The following is a description of a gene set: studied in species Mus musculus The portion of the actin cytoskeleton, comprising filamentous actin and associated proteins, that lies just beneath the plasma membrane. Mouse Gene Set: GOCC_CORTICAL_ACTIN_CYTOSKELETON, and this is the list of marker genes: Anln, Wasl, Flot1, Septin2, Mlph, Cobl, Cdh2, Myh9, Sptbn5, Gmfg, Ppp1r9b, Myzap, Tmc2, Myadm, Gys2 (glycogen synthase 2), Flot2, Actn3, Cfl1, Ppp1r9a, Cdh1, Hfe, Mtss2, Pls1, Calb1, Actn1, Shroom4, Snx9, Akap13, Slc2a1, Plekhh2, Cald1, Myrip, Coro1a, Trpv4, Myo1e, Wdr1 (NCBI Gene Id 28041), Llgl1, Maea, Sptb, Pjvk, Pdlim2, Rtkn, Piezo2, Hcls1, Rdx, Sptbn1, Cib2, Actn2, Pvalb, Iqgap1, Hip1, Prkcb, Ocm, Cotl1, Eef1a1, Cttn, Dbnl, Nf2, Sptbn2, Dbn1, Spta1, Scnn1a, Myo1a, Krt19, Fchsd1, Gmfb, Myo1f, Myh2, Med28, Cap1, Vcl (vinculin), Actr2, Pstpip1, Lancl2, Dlc1, Kncn, Lasp1, Dstn, Shroom1, Hip1r, Calb2 (NCBI Gene Id 12308), Actn4, Llgl2, Misp, Cldn5, Gsn, Piezo1, Shroom2, Sptan1, Rapgef3, Sptbn4, Shroom3